Given this list of marker genes Ifng, Prkcq, Cd55, Il18, Opa1, Gimap5, Cd3e, Irgm1, Nfkbiz, Ccr2, Il2rg, Shb, Brd4 (NCBI Gene Id 57261), Irf1 (interferon regulatory factor 1), Socs1, Malt1, Il4ra, Il23a, Ccl19, Nfkbid, Brd2, Cd28, Tgfbr2, Cd83, Tnfsf4, Xcl1, Il6, Foxp3, Klhl25, Mir326, H2-Ea, Nckap1l, Zbtb7b, Rara, Prkcz, Cd55b, Gimap3, Sash3, Hlx, Socs5, Cd24a, Cd160, Card11, Ccr7, Cd81 (NCBI Gene Id 12520, CD81 antigen), Nlrp3, Ripk2, Anxa1, Ep300, here is a description of the gene set: Mouse Gene Set: GOBP_POSITIVE_REGULATION_OF_CD4_POSITIVE_ALPHA_BETA_T_CELL_ACTIVATION Any process that activates or increases the frequency, rate or extent of CD4-positive, alpha-beta T cell activation. studied in species Mus musculus